Given this list of marker genes YPEL3, FBXL12, RPTOR, ZBTB37, FPGT, SCML4, CCS, SAMD3, UNK, SPRY2 (sprouty RTK signaling antagonist 2), CYP19A1, HSDL1, DZIP1, CBX7, TMEM241, ZXDC, USE1, TASL, TTC39C, D2HGDH (D-2-hydroxyglutarate dehydrogenase), SEC16A, VKORC1, CD55, F2RL1, DDRGK1, PER1, ZC3H6, GP2, CARD6, TMEM185B, ASTL, PNLIPRP1, CXCR6, NEU2, FBXO32, HERPUD2, OLFM5P, FOXP1, ARHGEF28, YPEL5, EZH1, HEXIM1, KDM5B, BEST2, KBTBD11, MAT2B, KRTAP5-1, RTP1, MAPK8IP3, ACSS2, H2AC6, GAB3, RPL19, MICU3 (mitochondrial calcium uptake family member 3), CX3CR1, TMEM71, GPR21, APTX, ADCK2, CDH1, NEURL3, HSD17B8, RNF166, CD226, MBLAC2, L3MBTL3, S1PR5, GIMAP3P, TSC22D3, CD96, BAG5, IFNA2, UPK3B, TOR4A, SMIM31 (small integral membrane protein 31), DGUOK, RAB5A, TCF7, TMEM135, TCP11L2, MPPE1, FAM161B, C19orf44, NFE2L1, KLRC1, EHD3, KAT6B, KCNJ8 (NCBI Gene Id 3764), STARD10, FOXO3, TESPA1, SNAPC4, DMRTA1, EPSTI1, CCDC171, F2RL2, ARHGEF12, C7, FOXJ2, AKAP8L, BTG1, USP3, H1-2, MAML2, TP53RK, CRIM1, NR1D2, TRAF1, SPINK4, ABTB3, PIK3IP1, KLHL14, ITPR2, SLC25A51 (NCBI Gene Id 92014), TANC1, SH2B1, ZHX2, SPATA6, NOP53, LYSMD1, LETM2, TXNIP, PACS1, HOMEZ, SFXN3, RNF167, IL7R, GABARAPL2, GRK1, CREBL2, VPREB1, EMB, HID1, KIZ, HRH2, TNFSF14, TDRD5, PUS3, VSIR, BMAL1 (basic helix-loop-helix ARNT like 1), PDE2A, VIPR1 (vasoactive intestinal peptide receptor 1), TMEM120B, SIDT1, ATP6V1G3, BCAS3, PNPLA7, ADAMTS6, RAP2A, SMNDC1, PHF21A, KISS1R, RPL4, CRTAM, PLA2G4E, BTBD6, ZNHIT6, ADRB2, here is a description of the gene set: Human Gene Set: GSE13547_WT_VS_ZFX_KO_BCELL_ANTI_IGM_STIM_12H_DN from publication Arenzana TL, Smith-Raska MR, Reizis B (PMID 19329779) The development, homeostasis and function of B lymphocytes involve multiple rounds of B cell receptor (BCR)-controlled proliferation and prolonged maintenance. We analyzed the role of transcription factor Zfx, a recently identified regulator of stem cell maintenance, in B cell development and homeostasis. Conditional Zfx deletion in the bone marrow blocked B cell development at the pre-BCR selection checkpoint. Zfx deficiency in peripheral B cells caused impaired generation of the B-1 cell lineage, accelerated B cell turnover, depletion of mature recirculating cells, and delayed T-dependent antibody responses. Zfx-deficient B cells showed normal proximal BCR signaling, but impaired BCR-induced proliferation and survival. This was accompanied by aberrantly enhanced and prolonged integrated stress response, and delayed induction of Cyclin D2 and Bcl-xL proteins. Thus, Zfx restrains the stress response and couples antigen receptor signaling to B cell expansion and maintenance during development and peripheral homeostasis. studied in species Homo sapiens Genes down-regulated in B lymphocytes stimulated by anti-IgM for 12h: wildtype versus ZFX knockout.